The following is a description of a gene set: Formation of hard tissues that consist mainly of inorganic compounds, and also contain a small amounts of organic matrices that are believed to play important roles in their formation. species: Homo sapiens Human Gene Set: GOBP_BIOMINERAL_TISSUE_DEVELOPMENT, and this is the list of marker genes: BMPR2, STIM1, BMP2K, TXLNG, FGFR3, ACTN3, BMPR1B, OTOP1, KLF10, TMEM38B, RSPO2, ITGB1BP1, SLC20A2, ZMPSTE24, RXRA, CYP27B1 (cytochrome P450 family 27 subfamily B member 1), FBXO5, FZD9, CNNM4, BGLAP, SLC8A1, PTH, FGF23, AXIN2, NBR1, CLEC3B, ADRB2, LEP, HTN3, HEY1, LOX, SRGN, PRICKLE1, PTK2B, COL1A1, COMP, AMELX, MATN1, SLC4A2, BMP4, SMPD3, TSPEAR (NCBI Gene Id 54084), CEMP1, STATH, ROCK2 (NCBI Gene Id 9475), SP7, LTF, OSR1, WLS, NOS3, ANKH, KL, SGMS2, LGR4 (NCBI Gene Id 55366), PHEX, COL6A1, MEPE, PPARA, BMP2, ODAPH, MGP, WDR72, DMP1, ITGB6, OC90, AMTN, PTN, SPP1, GREM1, BCOR, CCL3, FOSL2, IFT80, MMP20, BMP6, TRPM4, SOX9, FBN2, ZBTB40, NOTCH1, EIF2AK3, HEY2, TBX1, RFLNB, CCDC154, SBDS, GAS6, DDR2, PTH1R, MEF2C, MIR208A, ACVR2A, CER1, ENPP1, TMEM119, BMP7, IBSP, ATF4, NOTUM, RFLNA, TUFT1, FAM83H, AHSG, IFITM5, ACVR2B, ALPL, RXRB, FGR, OTOL1 (NCBI Gene Id 131149), CFTR, GATA1, AMBN, TENT5A, ADGRV1, COL1A2, HERC1, ATP2B1, DSPP, WNT4, IGF1, VDR, SLC24A3, ECM1, SMAD3, HACD1, CCR1, FBXL15, PKDCC, ATG4B, GPC3, SNX10, ADGRG6, WNT11, KLK4, ALOX15, BMPR1A, LTBP3, ROCK1, CCN1 (cellular communication network factor 1), HIF1A, MSX2, MMP13, ALOX5, TFIP11, P2RX7, RUNX2, FKRP, SLC20A1, FGFR2, AMELY, FAM20C, PHOSPHO1, ACVR1, TCIRG1, ERCC2, ROGDI, SBNO2, ISG15, WNT10B, GPM6B, SLC24A4, PTHLH, MINPP1, OSR2, TWIST1, ODAM, CEBPB, SUV39H1, S1PR1, TFAP2A, FAM20A, ANO6, ASPN, NELL1, NECTIN1, WNT6, ATRAID, FGFR1, TGFB1, ENAM, HTN1